Given this list of marker genes TLE4, PSMC5, PSMB7, AXIN1, SEM1, CTNNB1, TCF7, PSMA4, PSMC6, PSMA7, PSMA3, PPP2R5A, TCF7L2, RPS27A (ribosomal protein S27a), PSMD14, PSMB3, PSMD2, TCF7L1, TLE1, BTRC, TLE2, LEF1, CTBP1, PPP2R1B, APC, PSMD13, CUL1, PSMD1, PSMB5, UBB, PSMC2, PPP2CB, PSMB4, PSMB1 (NCBI Gene Id 5689), AMER1, PSMC1, PSMD8, PPP2R1A, PPP2CA, PPP2R5C, PSMB6 (NCBI Gene Id 95505), PPP2R5B, PSMC3, PPP2R5E, TLE5 (TLE family member 5, transcriptional modulator), PSMA2, PSMA1, TLE3, PPP2R5D, PSMD11, PSMD6, FRAT2, AXIN2, GSK3B, ZRANB1 (zinc finger RANBP2-type containing 1), CTBP2 (NCBI Gene Id 87435), ADRM1, PSMB2, RBX1, PSMD3, PSMA6, CSNK1A1, PSMD7, HDAC1, PSMC4, PSMA5, UBA52 (NCBI Gene Id 7311), SKP1, FRAT1 (FRAT regulator of WNT signaling pathway 1), PSMD12, UBC, MYC, here is a description of the gene set: The beta-catenin destruction complex plays a key role in the canonical Wnt signaling pathway. In the absence of Wnt signaling, this complex controls the levels of cytoplamic beta-catenin. Beta-catenin associates with and is phosphorylated by the destruction complex. Phosphorylated beta-catenin is recognized and ubiquitinated by the SCF-beta TrCP ubiquitin ligase complex and is subsequently degraded by the proteasome. part of: Signaling by WNT Reactome Pathway: Degradation of beta-catenin by the destruction complex species: Homo sapiens